Given this list of marker genes POMT2, COPZ1, HDAC3, ELK1, SHANK1, ZBTB7B, MYH9, THAP11, CDK20, PA2G4 (NCBI Gene Id 5036), TIMP4 (NCBI Gene Id 7079), ADAMTS6, BARHL1, MKNK2, PRRT2, SMARCA2, KCNQ3 (NCBI Gene Id 3786), PCDHGC3, BSN, RAVER1, PXN (NCBI Gene Id 80229), ATP2A1, COPS7B, SHISA6, FAM53C, SORT1, DNAJB12, SLC25A45, SPPL2B, ADCY9, SEMA6B, PLGLB1, PCDHGA12, NECTIN1, PLXNA4, PHF8, SLC6A17, MAP1A, ABCB8, PPP4R3A, FGFBP3 (NCBI Gene Id 143282), DPYSL4, GZF1, PCDHGA1 (protocadherin gamma subfamily A, 1), ANKRD52, FOXP4, BCL9, SRF, MBD1, BRPF1, CAVIN1, DYRK1B, PACSIN1, DHRS11, SPEG, GRIK3, UNC119, ATF7IP2, RAB43, C1QTNF6, CABP2, CASTOR2, HSPB6, SUSD6 (sushi domain containing 6), IFT140, LRRC15, LIMK2, PPP2R1A, GLP1R, FA2H, ZBTB7A, CABLES1, C6orf89, TREM1, MRO, ACY3, RNASE13, CDC42SE1, NAV1 (neuron navigator 1), RAB5C, N4BP1, SYNGAP1, SPOCK2, GNAO1, DTX4, CREB3L2, YPEL4, NCOA1, CNPY3, DAAM2, TMEM86A, VWC2, SPTB, KCNQ2, PDPR, SCAI, KIF5A, MGAT3, SPRYD3, BCAM, PHF19, COL5A3, TNRC6A, USP37, RAPGEFL1, PIKFYVE, SPINDOC, DDHD1, THEM5, ILRUN, C19orf84, GPSM1, DLK1, IQSEC3, NGFR, R3HDM4, SRRM4, CRYGN, FIGNL2, PDIA6, TMEM225B, NOVA2, TSPAN11, ZFP91, CELF3, NFASC, SPIB, GRAMD1B, PPARD, CAPN11 (calpain 11), GOLT1A, BBS1 (Bardet-Biedl syndrome 1), YBX2, UBTF, CST9, STXBP1, SLC7A8, PDX1, PIAS4, SHISA9, MEX3A, RNF26, CBL, MGAT5B, TAOK1, PROK1, PCDHGB3, STAT2, MIP, GNG7, NRBP1, BEST3, PROM2, PLP2, SMAP2, BACH2, HCFC1, DNM1, CASKIN1, TMEM63C, CIB2 (NCBI Gene Id 404086), SCAMP4 (secretory carrier membrane protein 4), BRF1, BSDC1, ZC3H18, PPP1R9B, OS9, VASH1, PHYHIP, SCRT1, LDLRAD2, CRY2, PRR12, PRKAR1B, PLGLB2, SPTBN4, TGIF1, PILRB, CSNK1A1, SLC18A1, DBNDD1, ASIC1, AMER1, PCDHGA7, CTDSP1, FHL3, CLSTN1, PRLHR, SMUG1, EEIG1, ATP5MC2, FLT4, NAA15, TRAF3, OLFML2A, SLC39A3, PATE3, PRSS55, EFNA4, SLC9A1, PLEKHH1 (NCBI Gene Id 57475), NACC1, B3GNT7, XIRP1, AP2A1, NCDN, FAM53A, ZNF385A, SIRPG, BTG2, LIF, SYP, HECTD4, IFI35, IQSEC2, SLC7A1 (NCBI Gene Id 6541), CENPB, MATN1, SV2A, CELSR2, SLC9A5, DES, TTBK1, CRABP2, TRIM3, SIDT2, PSMD1, LIX1L, YWHAE, CELF5, SORBS3, UNC5B, FSCN1, ATP8B2, PGAP3, MMP28, SEMA4G, RIMS3, CLASP1, PCDHGC5, CDR2L, ZDHHC3 (zinc finger DHHC-type palmitoyltransferase 3), HS3ST4, FBXO41, FAM131B, SOX12, DIRAS1, RTL8A, JPH4, CACNG7, JADE2, MOB3A, UBE2Q1, SYNDIG1L, MLLT1, MIDEAS, PRKACA, MEIS2, PYCR3, SPATA31D3, SREBF2, WNK3, B3GALNT2, PRSS53, CYP26B1, MAPK3, ZMYND11, MIEN1, CDKN1A, GLG1, PCDHGA5, EPHB4, B3GAT1, POU2F2, KIAA0930, NRL, LRFN2, CPEB3, ZSCAN31 (NCBI Gene Id 91921), SIRPA, HMGA1, ZFP3, IDS, PADI2, NBL1, FAM222B, KMT5C, STAT3, HOXB5, EAF1, PRND, AMOTL1, CFAP263, CS, BCAS1, NR1D1, ATXN2L, PDGFB, PCDHGA11, RD3 (NCBI Gene Id 343035), ARHGDIA, RAP1GAP2, RAB35, TTYH3, CNTNAP5, HABP2, PCDHGA9, NFIC, AGPAT1, TSPYL5, SNX33, SRGAP3, LRRC32, NOS1, TRIM66, ZC3H7B, APLP2, APLNR, PAX7, IER5, EXTL3, TMEM104, KIF18B, ZDHHC5, RPP25, PCDHGA3, HP1BP3, KIRREL3, ATXN1L, KIF13B, ZNF703, TRIM67, ITGA3, PFN1, MTSS2, CDC42BPA, ELAVL3, GTPBP1, CLCF1, UROC1, ARID3B, KDM5C, KRTAP10-11, GNB3, PFKFB2, PCDHGB7, PCDHGA8, DACT2, ZNF609, NAAA, NHERF2, FAM111A, RARG, URM1, PRX, DYRK2, MOGAT2, BEGAIN, PDE4A, SLC2A4, ARHGAP9, LMNA, ETNK1, PTPRU, ATN1, LRRN2, CTIF, SLC35C1, CNOT3, TNRC6B, MEST, GPD1, TULP1, PPT2 (NCBI Gene Id 9374), SCN4B, LYSMD1, AP3B2, PHF23, C11orf87, RTL8C, CACNB2, C1orf21, NEUROD2, MTCL2, ELF4, SCARA5, SLC7A6, EPHA8, AGO1, EPB41L1, CDK5RAP1, NFYC, OAF, PKLR, ADCYAP1R1, LDLRAP1, MACF1, PCDHGA10, SLIT3, AQP2, CDK18, OGDH, PDE1B, CD6, ARHGEF11, UBE2D4, VAT1, WHRN, VAMP2, IKZF3, CBX6, LANCL2, PURA, FXYD6, TAB1, PCDHGA2, IGF2, here is a description of the gene set: studied in species Homo sapiens from publication Chen Y, Wang X (PMID 31504780) Human Gene Set: MIR6825_5P Genes predicted to be targets of miRBase v22 microRNA hsa-miR-6825-5p in miRDB v6.0 with MirTarget v4 prediction scores > 80 (high confidence targets).